Given this list of marker genes LGALS1, TNFSF18, TBX21, JAK3, LOXL3, STAT5A, CD69, here is a description of the gene set: Any process that stops, prevents or reduces the frequency, rate or extent of T-helper 17 cell lineage commitment. species: Homo sapiens Human Gene Set: GOBP_NEGATIVE_REGULATION_OF_T_HELPER_17_CELL_LINEAGE_COMMITMENT